Given this list of marker genes MAGI1, CACNA1D, KCNN2, PRICKLE4, PALLD, TTN, NRAP, CACNA1C, PDLIM7, KCNA5, PPARG, PKD2L1, PKD2, PDLIM2, PDLIM5, PDLIM4, XIRP2, PDLIM3, MYOT, ADORA2A, PDLIM1, LDB3, LRRC10, DAG1, MYPN, SYNPO2, RARA, PTPRT, here is a description of the gene set: Human Gene Set: GOMF_ALPHA_ACTININ_BINDING studied in species Homo sapiens Binding to alpha-actinin, one of a family of proteins that cross-link F-actin as antiparallel homodimers. Alpha-actinin has a molecular mass of 93-103 KDa; at the N-terminus there are two calponin homology domains, at the C-terminus there are two EF-hands. These two domains are connected by the rod domain. This domain is formed by triple-helical spectrin repeats.